The following is a description of a gene set: Human neuronal differentiation alters responsiveness to innate immune stimuli and virus infections. We used microarrays to examine the transcriptional responses of the human BE(2)-C neuroblastoma cell line to infection with western equine encephalitis virus (WEEV). Human Gene Set: GSE16451_CTRL_VS_WEST_EQUINE_ENC_VIRUS_IMMATURE_NEURON_CELL_LINE_UP from publication Peltier DC, Simms A, Farmer JR, Miller DJ (PMID 20483728) studied in species Homo sapiens Genes up-regulated in the immature neuron cell line: control versus infected with western equine encephalitis viruss., and this is the list of marker genes: PWP2, FAM120AOS, DTWD2, IBTK, CLIP1, POLR1A, FAM117B, OSTF1, BOLA2, PIK3R5, ST8SIA1, DSE, MBOAT4, ARHGAP29, CERS6, SEMA4A, CNGA1, TGFBR3 (NCBI Gene Id 7049), PDLIM1, DZIP1, EEF1G, NACC2, PXYLP1, LMO4, PCCA, TDRP, TMEM273, PDE5A, HID1, POU2AF1, CCL5, SMURF2, HPCAL1, ATP1B1, MFSD6, SLC30A4, PRKAR2A, GNG8, RAPGEF4, IL21, TMEM41A, APPL2, UBXN11, CLTB, SEMA4F, DAPL1, DOP1A, C1orf35, SNN, ACADM, CARD19, METTL9, SLC16A5, ATXN7L3B, MYO10, SGK3, HS3ST3B1, GALNT10, EIF3I, PUS7L, TTC13, EMC10, MIA2, GRAMD4, MACROD1, POLR3E, POLR1G, POLR2H, ARL4C, STT3B, RRP15, GMFG, RGCC, RPS23, GPN1, PCCB, TBC1D16, CXCR6, PDLIM4, LDLRAP1 (NCBI Gene Id 81862), IKZF1, MRPL30, SESTD1, KLHDC1, PPIL4, TCF7, METTL13, CEP164, AQR, PIM2, C19orf38, CD2AP, RAB11FIP4, ACSS2, DHRS13, CMC1, KREMEN1, EHD3, UCHL3, NTRK3, CGAS, EPB41, CDH13 (NCBI Gene Id 1012), PAQR7, IL1RL2, TTYH3, MKS1, GPD2, CACNB1, LAIR1, QTRT1, ADH1C, PPIF, ADI1, SHLD1, LEF1, CYP2S1, MFHAS1, ATP6V0A2, MTFR1L, MRPL11, PEX12, PRMT3 (NCBI Gene Id 10196), BPNT1, KHDRBS3, ACVR1B, RNF32, SLC30A5, ATP8B4, DPY19L1, COMMD8, ITGB3, PCYOX1, MRPS18B, PAG1, MBOAT1, TMEM141, ITPR1, ATRAID, PALS2, AR, KLRD1, PUM3, EMG1, UBE3D, EIF2B3, GPR180, IL4, MBP, GZMK, CD200R1L, VIPR1, NLK, EPAS1, NUCKS1, UTP4, ATN1, TGFBR2, MAK16, ADGRG3, RSU1, RGMB, PIK3IP1, MPHOSPH9, PIP4K2A, MSRA, ATP10A, NME4, ACTN1 (actinin alpha 1), UTP14A, WSCD2, ATP6V1H, ACP3, UBAC1, RUNX3, RARS1, COQ10A, GGT5, KCNMB4, RNF122, RCC1L, FNTB, LYPD6B, RFLNB, THEMIS, METTL1, LHFPL3, TMEM31, GAB3, FBP1, HDDC2, DAAM1, LRRC75B, RNF166, SCP2, ELOVL7, GGT1, ENC1, USP36, EVI2B